Given this list of marker genes TYW1, CFP, NRIP1, EGR3, NAB2, MOB4, MBD4, CEP350, RAD54B, GZMM, HOPX, SCML1, ITPKB, CAB39, TTC31, KLHDC4, DOK2, AUTS2, RBM48, RBM38, BTBD1, ANTKMT, UBA3, TUBA4A (NCBI Gene Id 93373), PIK3C2A, PDE3B, CDH1 (NCBI Gene Id 999), ZFYVE16, TOB1, CDK11A (NCBI Gene Id 986), KLF2, TMEM267, PJA1, ATG12, TSPYL1, HBP1, ERGIC2, PPM1B, KDM6B, INPP4A, LINC00623, IL23A, FLT3LG, GPR18, GSK3B, MRPS31, RAB3GAP2, TBC1D8, TGOLN2, COL18A1, NGDN, WDR26, NT5E, SH3YL1, ASTE1, ALG6, COL6A3, RAP2C, PASK, GALNT10, SIRT7, EZH1, ZBTB24, TIAM1, POLG2, MED1, CYB5R1, ZNF137P, CEBPG, TSPAN14, TXK, CCNT2, SPG11, TMEM204, ACTN1, STAT1, BCOR, NDNF, AP1G2, PLAG1, ATP8B1, PTPN4, OXLD1, MTMR1, ALDOC, ADD3, TAX1BP1, TNFRSF25, IGFBP2, ZNF200, SLC30A1, JMJD6, THUMPD1, IL2RB, OAS1, AKAP10, GMIP, STX16, CDK13, PARP12, ZBTB18, KRAS, CAPN2, PRPF3, IRF4, KIAA0232, RBM19, JUNB, SLAMF1, ING1, AOAH, CCL5, LRBA, ELMO2, STAG2, MAN2A2, KLRC3, PTPRC, RAB3GAP1 (NCBI Gene Id 338380), RAB33A, RIGI, HERPUD1, USP16, ITFG1, PRL, DNAJB14, SAYSD1, WDR59, PPP2R5E, TRAK2, CD248, MVP, ING3, KLRB1, RCAN3, NPAT, LCP2, TBC1D2B, PDCD4-AS1, S100A10, TRBV10-2, MTMR6, SEMA4D, TPST2, PCMTD2, FBXL4, CUL2, VPS13B, ATP8A1, RBL2, EGR2, PRPF40A, SNAPC5, PIGB, CD28, ANKRD49, NSMF (NCBI Gene Id 349336), COQ10B (coenzyme Q10B), CREBBP, MACO1, TNKS, ZNF274, ATP13A1, CAMK4, BCL2, SRF, RRN3P1, INTS6, ELK3, PTPRA, SEC24B, IL6ST, KLHL2, ALOX5AP, GZMK, MTUS1, SLC16A10, MARK3, COA1, LTA, C1GALT1C1, PPP2R5A (protein phosphatase 2 regulatory subunit B'alpha), CDK17, ST3GAL5, GOSR1, MYOM2 (NCBI Gene Id 9172), NSUN5P1, WDR44, MED23, TRAF4 (TNF receptor associated factor 4), PCSK7, NELL2, ZNF623, SLC18A2, KDM7A (NCBI Gene Id 80853), ARID4B, IL27RA, CHI3L2, NR4A2, ROBO1, here is a description of the gene set: from publication Szanto A, Balint BL, Nagy ZS, Barta E, Dezso B, Pap A, Szeles L, Poliska S, Oros M, Evans RM, Barak Y, Schwabe J, Nagy L (PMID 21093321) species: Homo sapiens Genes down-regulated in macrophages (12h): IFNG, TNF and rosiglitazone versus rosiglitazone. Human CD14 positive monocytes were purified from healthy volunteers’ blood and cultured in vitro for 4, 12, 24, 72 hours. While culturing, macrophages were activated alternatively with interleukin-4 (IL-4 100 ng/ml) or classically with interferon-gamma (IFNg 100 ng/ml)+tumor necrosis factor (TNF 50 ng/ml) or left without activation. Simultaneously, macrophages were also treated with vehicle (DMSO:ethanol) or 1mM synthetic PPARg agonist, Rosiglitazone. We used Affymetrix microarrays (U133Plus 2.0) to analyze activation and PPARg-induced gene expression changes. Human Gene Set: GSE16385_IFNG_TNF_VS_UNSTIM_MACROPHAGE_ROSIGLITAZONE_TREATED_DN